Given this list of marker genes CDK16, WARS1, SCARB1, ARFGEF3, PHC2, DPF2, CPSF6, SOX11, ACER2, MAP3K11, EIF5A2, GTPBP2 (GTP binding protein 2), BRPF3, MTUS1, SSTR3 (somatostatin receptor 3), FUT4, ASB13, FCHSD1, SLC17A7, KCNH7, PAFAH1B1, ANKRD50, LFNG, CBX7, NKAPD1, DYNLT3, SLC7A1, SZRD1, FAM131B, SAMD10, MAPK14, IRF4, DCTN1, STAT3, CPEB3, SLC35A4, RETREG2, SLC7A6, ALPK3, RHOT2, M6PR, HIVEP2, FAM118A, UBE2W, RETREG3, ESYT1, TBX4, FLOT2, EAF1, PTPRF, MADD, HOXB3, CGN, MAP3K10, SPEG, IL16, NEU1, KCNS3, GRSF1 (NCBI Gene Id 2926), ZFHX2, LRFN2, KHNYN, GGT7, DNAJB5, RABL6, MIDEAS, ITGB3, AP4E1, PHYHIP, DOCK3, VANGL2, DICER1, HMGB3 (high mobility group box 3), CACNB1, NECAB3, LYPLA2, CDR2L, TEF, BSN, APOBEC1, MASP1, ATP5MC2, PAPOLA, MKNK2, ADCY1, DAG1, MYT1, ETV6, PCSK7, XKR7, GGA2, SYN2, CNNM1 (cyclin and CBS domain divalent metal cation transport mediator 1), MYLK, RBM7, LIMD2, NCOR2, GANC, SLITRK6, UVRAG, SGPL1, CASP2, SRRM3, CORO2A, SORT1, ITGA9, VCPIP1, BMF, DIS3L2, KLC2, NCAN, SOCS4, IST1, MEMO1, ABCC5, VDR, SH3BP4, MCL1, DENND6A, ABTB1 (ankyrin repeat and BTB domain containing 1), LINC02145, PRDM1, LRP4, USP37, MAMDC2, MXD4, ST8SIA4, MAP2K7 (mitogen-activated protein kinase kinase 7), TRIAP1, FBXW4, ZNF236, BAP1, RTN2, EIF4EBP1, CCNJ, ETS1, KLHL24, OSBPL9, MLF2, IQSEC2, RNF44, GRB10, ZBTB7A, CD34, ATP10D, MYO18A, TRPS1, PHOX2B (paired like homeobox 2B), BRPF1, ENTPD4, PARP14, NUP210, ZNF76, RFXANK, EVA1A, SEC31B, RBM38, PODXL, USP12, SLC25A15, NHSL3, PPP1CA, TP53INP1, RPS6KA1, MAN1B1, SEMA4B, SEMA4C, GPC4, ATOH8, NEFM (neurofilament medium chain), UBE2R2, RET, ST6GAL1, TMPRSS13, SLC38A9, GOPC, BAZ2A, SIRT7, BMPR2, BCL9L, RHOQ, TMEM168, KMT5C (lysine methyltransferase 5C), MMP11, SLC8A2, PPP4R3A, RAB8B, VPS4B, ZSWIM4, SATB2 (SATB homeobox 2), DDX42, BAK1, GALNT14, ABR, SH3BP5L, SLC39A9, ASIC1, ORC2, UBE2G1, LACTB, HCN4, IP6K1, ABHD3, MTMR3, NIN, TGOLN2, ZNF691, EMID1, HOMEZ, PCGF6, ATXN1, ADAM9, DIRAS1, OAZ2, DERPC, E2F3, TBC1D1, NIPA1, ZBTB47, RUFY3, SERTAD3, ANTXR2, KCTD21, PLAGL2, TAF9B, EPB41L4A, SPTB, RNF144B, ADGRB1, CRB2, SYVN1, DVL3, SEMA4F, BCLAF3, PAN2, SLC4A4, KCNIP3, PPME1, MED15, GRIN2A, MEIS2, SEMA4D (NCBI Gene Id 349236), PLXNA1, PELI2, TRAPPC14, LIFR, UBTD1, OLFML2A, ABHD6, AGO2, TLK2, SRF, FOXS1, PTPN18, ADD2, TOR2A, ZFYVE1, ZNF385A, MEGF8, NIBAN2, STC1, DLL4, CSNK2A1, TMEM161B, ELOVL6, MIB1, RAPGEFL1, SCN2B, CASC3, TRIL, JADE2, LNPEP, MFSD13A, WIPF2, FAM78A, SMARCD2, SUV39H1, STARD13, UBE2L3, PCTP, TRAPPC6B, PPP2R5C, RAB3D, DALRD3, HOXC6, COPS7B, FNDC3B, ADAM11, EIF1AD, SARM1 (NCBI Gene Id 23098), RNF121, SLC27A4, FAM53C, TXNRD1, LOXL1, PPAT, ASB6, SET, IER2, MAP6, SMURF1, LBH, MFN1, RNF40, NT5DC1, ANPEP (NCBI Gene Id 290), ATP1B4 (ATPase Na+/K+ transporting family member beta 4), MSI1, NRM, TRIM71, CDC42SE1, IKZF4, GALNT7, TBC1D25, CEP85, SLC4A10, SNAI1, ESRRA, VEGFA, LIN28B, UBN1, SMG1, ARID3B, CSDE1, KLF13, ULK3, DRAM2, CCDC71L, HIC2, TSEN54, here is a description of the gene set: Genes having at least one occurence of the motif CTCAGGG in their 3' untranslated region. The motif represents putative target (that is, seed match) of human mature miRNAs hsa-miR-125b and hsa-miR-125a (v7.1 miRBase). Human Gene Set: CTCAGGG_MIR125B_MIR125A studied in species Homo sapiens